The following is a description of a gene set: species: Homo sapiens Human Gene Set: GOMF_AMIDE_BINDING Binding to an amide, any derivative of an oxoacid in which an acidic hydroxy group has been replaced by an amino or substituted amino group., and this is the list of marker genes: PNPLA3, ITGAM, ACBD5, TLR10, EPHA4, ITM2B, INHBA, FASN, PPID, LDLRAP1, FBXO2, PPIAL4E, FPR2, NLGN1, PTH1R, GSS, GPRASP2, PLA2G4A, SLC46A1, BCHE, HCRTR2, FKBP5, RYR2, APOA1, NPR1, CALCR, PPIC, APBB1, MARCO, ACAT1, DBI, CLU, AGER, GSTM4, DHFR, MGST2, GHSR, MAG, FKBP4, RAMP2, ACBD3, CALCRL, LRPAP1, PHB2, GSTM2, FOLH1, PFDN2, APP, NPR3, ACBD6, PFDN1, GRIA1, PPIAL4A, ATP1A3, CERT1, LBP, SRD5A1, CACNA1B, PTH2R, C2CD2L, SRD5A2, ITGA2, PFDN5, IDE, PANK3, CSF2RA, CRHR2, VBP1, PPIH (NCBI Gene Id 10465), LILRB1, IL23R, NGFR, FKBP3, CD1D, CCKAR, C1QA, GRIN2A, PTGES2, HLCS, CRHBP, PSAP, HMGCR, CLIP3 (CAP-Gly domain containing linker protein 3), FKBP1B, HSPG2, CLSTN1, GCDH, PPIAL4C, GIPR, IAPP, PPIAL4F, APBA2, PANK1, LDLR (low density lipoprotein receptor), PFDN4, GRIA3, FTCD, MCCC1, ACHE, CACNA1A, PRNP, ADRB2, NFATC1, EPHB2, MAPK8IP2, IZUMO1R, DHFRP1, MSR1, PICALM, CD1C, CMKLR1, ADCYAP1R1, CD36, RXFP2, ARMCX5-GPRASP2, NOD2 (NCBI Gene Id 8135), TM2D1, PLEKHA8, SCTR, FKBP2, PLEKHA8P1, SOAT1, GHRHR, ACACB, INSR, ITGB2, BACE1, LRP1, ACBD7, PPIF (NCBI Gene Id 10105), GLP1R, FZD6, GNMT, NAA80, TLR2, MTHFS, COL25A1, AVPR1A, PRLR, APOE, LAPTM4B, SCARB1, LDLRAD3, NPY4R, APBA3, CLN8, CD1A, GHR, GSTM1, GRIA2, RAMP1, TMEM120A, APBB3, FCGR2B, TREM2, PPIE, VIPR1 (vasoactive intestinal peptide receptor 1), GRIN1, ECI2, ACBD4, EDNRB, ECE1, HCRTR1, PIK3R1, P2RX1, GLP2R, GALR3, CD74, FTCDNL1, LRP8, NQO2, PPIG, FOLR3, GSAP, TGFB2, SORL1, CPTP, MC3R, ITM2C, FKBP10, ACOT7, IGF1R, NKTR, CRYAB, FKBP1A, SCP2, PLTP, GLTPD2, CRHR1, VDAC1, FOLR2, CD1E, TLR1 (NCBI Gene Id 7887), VIPR2, CMKLR2, SLC19A1, MAP1LC3B, FOLR1, FZD5, PPIA, ACVR1, PC (pyruvate carboxylase), APBB2, FZD4, UROS, SLC40A1, RTN4R, RAMP3, GSTM3, PCCA, CHRNA7, APBA1, LANCL1, NPR2, KIR3DL1, TLR6, TYMS, PPIAL4H, ACADVL, GALR2, PFDN6 (NCBI Gene Id 10471, prefoldin subunit 6), SOAT2, CST3, ITM2A, GRIA4, LILRB2, DLGAP3, MMACHC, PGRMC1, LEPR, PTGES, GRIN2B, TLR4, PPIAL4D, FKBP6, VDAC2, GLTP, CCKBR, PPIB, CD300LF, GALR1, FSHR, FKBP7, PPIAL4G, TAF1, CD1B, LILRB3, GCGR, EPDR1